The following is a description of a gene set: studied in species Homo sapiens Apoptotic cleavage of cell adhesion proteins Human Gene Set: REACTOME_APOPTOTIC_CLEAVAGE_OF_CELL_ADHESION_PROTEINS, and this is the list of marker genes: CTNNB1, OCLN, TJP2, CASP3, DSG2, TJP1, DSG1, DSG3, DSP, PKP1, CDH1 (cadherin 1)